The following is a description of a gene set: An increased concentration of glutaric acid in the blood. Elevated circulating glutaric acid concentration studied in species Homo sapiens Human Gene Set: HP_ELEVATED_CIRCULATING_GLUTARIC_ACID_CONCENTRATION, and this is the list of marker genes: SUGCT, GCDH, ETFB, ETFA, ETFDH (NCBI Gene Id 2110), DNAJC19